The following is a description of a gene set: Human Gene Set: HE_LIM_SUN_FETAL_LUNG_C1_CLUB_CELL species: Homo sapiens from publication He P, Lim K, Sun D, Pett JP, Jeng Q, Polanski K, Dong Z, Bolt L, Richardson L, Mamanova L, Dabrowska M, Wilbrey-Clark A, Madissoon E, Tuong ZK, Dann E, Suo C, Goh I, Yoshida M, Nikolić MZ, Janes SM, He X, Barker RA, Teichmann SA, Marioni JC, Meyer KB, Rawlins EL (PMID 36493756) Club, and this is the list of marker genes: NDUFA4L2, ERP27, HLA-B, FMO2, RUNX1, HS3ST1, SLPI, ARHGEF38, CA8, KLK11, EPAS1, MUC20, NIBAN1, FCGR2A, KDR, SCNN1B, CLIC5, STEAP4, PAPSS2, SERPINI1, SPARCL1, DPYD, SCGB1A1, ELAPOR1, PRSS12, ISG20, KLK10, CRTAC1, CP, SCGB3A1, CRIM1, BHLHE40, AGR3, NEGR1, CCNO, EHF, TRIM22, CTSW, MLPH, SPNS2, CFH, MET, LIPH, NXPH4 (neurexophilin 4), GRHL1, ARFGEF3, SPINK5, CFHR1, SFTA1P, SPINK1, TMC5, LMO3, SULT2B1, KRT7, SERPINA1, ROBO2, AARD, ST6GALNAC1, SCNN1G, C3, SIX1, ANXA1 (annexin A1), SLA, IFITM1, S100P, PAG1, SMIM22, RHOV, CAPS, CYP2B6